The following is a description of a gene set: from publication Durante MA, Kurtenbach S, Sargi ZB, Harbour JW, Choi R, Kurtenbach S, Goss GM, Matsunami H, Goldstein BJ (PMID 32066986) studied in species Homo sapiens Human Gene Set: DURANTE_ADULT_OLFACTORY_NEUROEPITHELIUM_MATURE_NEURONS, and this is the list of marker genes: MPZL1, OAZ2 (NCBI Gene Id 4947), ENO2, CALB2, TSPAN7, HTATIP2, GFY (NCBI Gene Id 647557), SYT1, EFHC1, TTC9B, UCHL1, TTLL7, MLF1, IGSF8, MAP1B, LRRIQ1, ATP6V1G1, R3HCC1, EFNA5, PODXL2, NDFIP1, ADISSP, TAGLN3, SARAF, GDI1, RTN1, P4HTM, CFAP126, EFNA3, CIBAR2, IMPDH1, STMN4, CAPS, IFI27L2, COX5B, MIEN1, SERPINE2, PSAP, FAM131C, SPAG16, CALM1, SPMIP6, RAP1GDS1, ELAVL3, PCSK1N, LINGO2, GLCCI1, DNER, EFHD1, COQ4, RUNDC3A, STOML3, TUBA1A, SNCA, LINC01548, CHGA, CFAP144, GDAP1, TSHZ2 (NCBI Gene Id 7765), H2BC21, WDR54, TSPAN3, IP6K2 (inositol hexakisphosphate kinase 2), SPEF1, SNAPIN, CCDC157, CYSTM1, GABARAPL2, SELENOT, ATF5, HBA1, NSG1, RTP1, KSR2, ORMDL3, TOM1 (NCBI Gene Id 10043), KIF9, HAGHL (NCBI Gene Id 84264), LHX2 (LIM homeobox 2), GNAL, GNG13, MORN2, CCDC184, CETN2, STOM, ATOX1, FXYD6, KAT6A, FAIM2, GAP43, JAKMIP1, EFR3B, TUBB2B, PPP1R1A, COMMD8, SYT5, SDC3, C21orf58, AGBL4, NCAM1, SCGB2A1, RFX8, SPINT2, EBF3, CACNB3, PDE6D, CALM2, NDUFA5, PLEKHB1, PPA1, CLGN, ADCY3, RSPH1 (NCBI Gene Id 89765), MAPK10, VAMP2, RETREG1, APLP1, KLC2, FGF12, TMPRSS6, MNS1 (NCBI Gene Id 55329), ARL3, CFAP276, FMN2, OLFM1, BEX1, ATP1B1, CBX4, MSI2, PSMC5, TERF2IP, CALM3, NICOL1, RUFY3, PCDH9, MGST3, RTN3, TPPP3, GPX2, PAFAH1B3, KIF3A, JAG1, NXNL2, RNF182, IGSF10, CKB, IFI27, SMIM35, RFK, REEP1, RIC8B, TMBIM6, EPCAM, PRXL2A, OSCP1, LINC00642, SNAP25, GNB1, PIGU, MT1F, TRIB3, CUTA (NCBI Gene Id 51596), SGPL1, CYB5R1 (cytochrome b5 reductase 1), EMX2, EBF2, NRXN1, CFAP69, DUSP26, SCN9A, CENPV, SCG3, STMN2, FSTL5, QPCT, UCP2, C11orf97, IFT27, SPEF2, ARPP21, C7orf57, KIFAP3, TKTL1, KIF22, SPOCK1, NEFL